The following is a description of a gene set: Human Gene Set: GOBP_METHIONINE_BIOSYNTHETIC_PROCESS species: Homo sapiens The chemical reactions and pathways resulting in the formation of methionine (2-amino-4-(methylthio)butanoic acid), a sulfur-containing, essential amino acid found in peptide linkage in proteins., and this is the list of marker genes: BHMT, APIP, MTRR, ENOPH1 (enolase-phosphatase 1), BHMT2, MTR, MTHFD1, ADI1